The following is a description of a gene set: Beta-catenin phosphorylation cascade Human Gene Set: REACTOME_BETA_CATENIN_PHOSPHORYLATION_CASCADE studied in species Homo sapiens, and this is the list of marker genes: PPP2R5A, FRAT1, PPP2R5D, GSK3B (NCBI Gene Id 2932), AMER1, PPP2R5E, PPP2R1B, CTNNB1, CSNK1A1, PPP2CB, PPP2R1A, PPP2R5B, APC, PPP2CA, PPP2R5C, AXIN1, FRAT2